The following is a description of a gene set: Upper-limb joint contracture Human Gene Set: HP_UPPER_LIMB_JOINT_CONTRACTURE species: Homo sapiens A limitation in the passive range of motion of a joint of the upper limb resulting from loss of elasticity in the periarticular tissues owing to structural changes of non-bony tissues, such as muscles, tendons, ligaments, joint capsules or skin., and this is the list of marker genes: ADSS1, H4C9, UBA1, RYR3, SMOC1, HNRNPA1, OCRL, PRG4, P4HTM (prolyl 4-hydroxylase, transmembrane), KY, ALDH18A1, CADM3, KIAA0319L, DOK7, LAMB3, POLR3GL, MAFB (MAF bZIP transcription factor B), DLL3, TBX2, RMRP, HACD1, SPRTN, RERE, DYRK1A, GDF5, TGFB3, EXTL3, MAP3K7, TNNI2, TGFB2, CUL4B, RTL1, KCNK9, SLC39A8, GNPTAB, COG8, MEG3, WNT7A, KRT14, TMEM222, SLC29A3, ITGA7, TWIST2, SVIL (NCBI Gene Id 6840), PDGFRB, COL25A1, FZD2, PRKCZ, DLG5, SNRPB (NCBI Gene Id 6628), ECEL1, SKI, NALCN, ESCO2, DHCR24, HOXD13, MYH3, SCARF2, KIF22, WNT5A, IKBKG, ZNF407, BCOR, MYL1, HS2ST1, ACTA1, HSPB1, LIFR, SMG9, KDM5C, CASZ1, RARS2, NDRG1, TCTN3, B3GALT6, DMD, EMG1, DVL1, MORC2, TGFBR2, SPTLC1, SPEN (spen family transcriptional repressor), SPTAN1, FGD1, SPG11, TRPV4, CCN6, NEFL, FAT4, PIGY, HK1, TLK2, SUZ12, ERCC2, PLEKHG5, MED12, IGHMBP2, CSGALNACT1, SIK3, CDC45 (NCBI Gene Id 8319), MYL11, ERGIC1, KAT6B, WDR73, NR4A2, FBN2, IL6ST, ADAMTS15, YRDC, SELENON, RTTN, SRD5A3, SYNE2, TMEM218, PIK3C2A, TDO2 (NCBI Gene Id 6999), RAB23, LGI4, SMAD2, PYCR1, GNS, SLC35A2, ORC4, TBX15, PLOD2, MECP2, PSTPIP1, GLI3, FLNA, COL11A2, FBXO28, NUP107, SYNE1, MYOD1, ERLIN2, FILIP1, HSPG2, TBR1, XYLT1, TPM3, SIGMAR1, GPC4, MYBPC1, ADAMTSL2, SYT2, CANT1, PRDM16, NOG, NUP133, FBN1, MESP2, COL6A3, DDR2, CDH3, KRT1, UROS, CTDP1 (NCBI Gene Id 9150), RNU4ATAC, ALX3, ARPC4 (NCBI Gene Id 10093), ZMPSTE24, FUS, TGFBR1, FDFT1, AMER1, MKS1, LMX1B, HES7, CTCF, COG5, NAA10, TOR1AIP1, CCN2, TP53RK, JAG2, CCBE1, FKTN, FBXW11, ACTG2, CDT1, CCR6, MED25, FKBP10, ERCC1, UPF3B, ERCC6, FHL1, SHH, CNTN1, POR, GPKOW, TOR1A, ALS2, PYROXD1, TNNT3 (NCBI Gene Id 8044), IPO8, ARID1B, PTRH2, JARID2, SLC25A46, COX11, GPC3, SMC1A, IGF2, KIF5A, ADGRG6, SMAD3, DHX16, MYL2, TPRKB, COL2A1, EMD, MEGF10, MBTPS2, ASXL3, FKRP, IDS, KIF21A, GON7, UNC80, KRT16, FGFR3, LUZP1, PEX5, ADAT3, FERMT1, GMNN, PI4KA, SCN4A, SLC39A13, ADAMTS3, KMT2A (lysine methyltransferase 2A), IRF5, ORC6, ALG3, FLVCR1, PIEZO2, SLC26A2, ECE1, SLC35A3, NUP88, LARGE1, ROR2, GJA1 (gap junction protein alpha 1), SH3PXD2B, FBXO11, TBC1D2B, LAGE3, PEX1, NXN, GLDN, PMP22, CPT2, RAB3GAP1, ASXL1, CAPN3, SLC6A9, FGFR1, POLR3A, ORC1, TMEM70, ERCC5, MAGEL2, NLRP3, GNPTG, INF2, KMT2B, AUTS2, MUSK, NIPBL, PSMB8, RSPO2, KRT9, WDR4, CHRNG, L1CAM, CDC6, UBAP2L, ATR, PORCN, PDPN, COL6A1, COL11A1, ANTXR2, RIPPLY2 (NCBI Gene Id 134701), EFNB1, RPL10, KCNAB2, CLCF1, CHST3, TFAP2A (transcription factor AP-2 alpha), TBX3, COL1A1, ANO5, PIGA, APC2, PDXK, GJB2, TUBA1A, SCYL2, TNNT1, DVL3, CRKL, GNPNAT1, DHODH, CRLF1, MMP23B, DLK1, HINT1, TPM2 (tropomyosin 2), OSGEP, RAPSN, PHGDH, EZH2, LMBR1, TGDS, CCDC22, KDM5B, PLOD1, MAPK1, SNUPN, SOX9, ZDHHC9 (zinc finger DHHC-type palmitoyltransferase 9), COL12A1, LMNA, PQBP1, SLC18A3, TP63, NSD1, GNB2, TMEM43, PIGL, NOD2, PAX3, ERI1, IDUA, MAP3K20, HLA-DRB1, TUBB3, CAV1, NEDD4L, PTDSS1, MMP2, B3GAT3, SMARCAD1, UBE4B, LFNG, GDAP1, MEGF8, BCR, PEX6, TRPS1, GABRD, PLOD3 (NCBI Gene Id 8985), SIN3A, COL6A2, ALX1, LAMA2